The following is a description of a gene set: Expression profiling of Rag2-deficient Ets1++ and Rag2-deficient Ets1-- mature NK cells and WT bone marrow progenitors, WT T cells, and WT Pro B cells Human Gene Set: GSE37301_HEMATOPOIETIC_STEM_CELL_VS_MULTIPOTENT_PROGENITOR_UP Genes up-regulated in hematopoietic stem cells versus multipotent progenitors. from publication Ramirez K, Chandler KJ, Spaulding C, Zandi S, Sigvardsson M, Graves BJ, Kee BL (PMID 22608498) studied in species Homo sapiens, and this is the list of marker genes: MYLK (myosin light chain kinase), CSF3R, C1QBP, TYR, AHI1, DFFB (DNA fragmentation factor subunit beta), FXR1, FZD1, SOX5, FOXD4L1, PAQR7, OPN1SW, MTFR1L, STK24, PSMD5, FOXO4, NREP, PSCA, KCNJ4, F2R, MFSD4A, RAB5B, EPB41L4A, KAT2A, KRT71, SGO1, SOCS3, FPR3, EFHD2, TET1, SLC27A1, MYH14, PLCG2, ARMC1, EPO, CDR2L, PTGDS, ACRV1, SH3GL2, HK2, ADAD1, UGT2B10, VAMP1, RARA, ELMOD3, MLF1, SLC8A1, E2F5, STC1, FZD4, TCL1A, SLC39A4, CA1, DMP1, CIT, UROS, C16orf89, CES1, DBF4, DNASE1L3, CPT2 (carnitine palmitoyltransferase 2), UHMK1, MSH3, SEMA3F (semaphorin 3F), PCSK6, APOBEC1, CACNG1, SLC7A9, SNX12, TRDMT1, HES6 (hes family bHLH transcription factor 6), AAK1, ADPRS, SRPK2, SOX6, DDX46, FGFR3, ACSL1, BTC, HSDL2, MMP15, TARDBP, SLC30A1, RAI2, PLA2G5, TTC7B, ZW10, CCL17, DLG3, SKA2, PDE1A, PRR5, SLC1A2, GCSAM, CRX, POM121, OXSM, PIGR, RAD50, HSD17B3, RYR2, PTK2, MTMR10, POLA1, PRKCQ, LHX9, SOX13 (SRY-box transcription factor 13), BLK, KL, TNFSF10, SH3BGR, NDUFB3, DNM1L, RGCC, ATP9A, ABCB4, CYTH3, RGS3, PTRH2, AURKB, KPNA6, MSH6 (mutS homolog 6), PLXND1, KCNU1, LRBA, INO80C, HSD17B11, RASGRP2, SYT3, FKBP4, GABRA6, CELF2, MYF5, ABCB9, KCNJ2, PABPN1, SLC35G6, NANOG, BTF3L4, ETV4, SLC52A2, DRD4, FAM107B, DLX5, PRSS8, B4GALT6, TLL1, HGS, D2HGDH, CHRNA7, SPINT1, DICER1, AMOTL2, SYPL2, TENT5A, FAM83H, PIK3CD, TMEM150A, ISL1, CALR, IFNA1, GPR37, NR1I3, SNTB1, MPL, USP34, STIL, PAK3, IGFALS, HYOU1, ADIPOR1, SLC39A6, MEF2C, MME, MPZL2, TECTA, ASH2L, WNT5B, UCHL1, PTK2B, LENG8, PLEKHA5, ZIK1, CAPN2, ABCD3, BMPR1A, EEIG1 (NCBI Gene Id 90676), RPP14, SPRYD7, FAF1 (Fas associated factor 1), NUP85, MDM4, TNNC1, GDI1, SELENBP1, C9orf85, INTS5, RAB10, PEX14, GPX1